Given this list of marker genes RRP8, USF2, SRF, USF1, SUV39H1, KAT2B, MLXIPL, SIRT1, OGT, here is a description of the gene set: studied in species Homo sapiens Human Gene Set: GOBP_REGULATION_OF_TRANSCRIPTION_BY_GLUCOSE Any process involving glucose that modulates the frequency, rate or extent or transcription.